The following is a description of a gene set: studied in species Mus musculus The chemical reactions and pathways involving benzene, C6H6, a volatile, very inflammable liquid, contained in the naphtha produced by the destructive distillation of coal, from which it is separated by fractional distillation, or any of its derivatives. Mouse Gene Set: GOBP_BENZENE_CONTAINING_COMPOUND_METABOLIC_PROCESS, and this is the list of marker genes: Ugt2b1, Kyat3, Acaa1b, Cyp4b1, Aadat, Ido1 (indoleamine 2,3-dioxygenase 1), Txnrd1, Ugt1a6b, Kmo, Fah, Gstm5, Aldh8a1, Cyp1b1, Acaa1a, Th, Gstm7, Tdo2, Kyat1, Gstm3, Gstm4, Gstm6, Ephx2, Pon3, Haao, Ugt1a1, Srd5a2, Afmid, Hao2, Ugt1a6a, Star, Ido2, Kynu